Given this list of marker genes PBX1, FCRL4, ARNT, HSP90AA1, PRRX1, NTRK1 (neurotrophic receptor tyrosine kinase 1), MLLT11, SDHC, PRCC, FCGR2B (NCBI Gene Id 2213), CDC73, MUC1, BCL9, TPM3, here is a description of the gene set: from publication Myllykangas S, Himberg J, Böhling T, Nagy B, Hollmén J, Knuutila S (PMID 16751803) Human Gene Set: MYLLYKANGAS_AMPLIFICATION_HOT_SPOT_24 DNA copy number amplifications activate oncogenes and are hallmarks of nearly all advanced tumors. Amplified genes represent attractive targets for therapy, diagnostics and prognostics. To investigate DNA amplifications in different neoplasms, we performed a bibliomics survey using 838 published chromosomal comparative genomic hybridization studies and collected amplification data at chromosome band resolution from more than 4500 cases. Amplification profiles were determined for 73 distinct neoplasms. Neoplasms were clustered according to the amplification profiles, and frequently amplified chromosomal loci (amplification hot spots) were identified using computational modeling. To investigate the site specificity and mechanisms of gene amplifications, colocalization of amplification hot spots, cancer genes, fragile sites, virus integration sites and gene size cohorts were tested in a statistical framework. Amplification-based clustering demonstrated that cancers with similar etiology, cell-of-origin or topographical location have a tendency to obtain convergent amplification profiles. The identified amplification hot spots were colocalized with the known fragile sites, cancer genes and virus integration sites, but global statistical significance could not be ascertained. Large genes were significantly overrepresented on the fragile sites and the reported amplification hot spots. These findings indicate that amplifications are selected in the cancer tissue environment according to the qualitative traits and localization of cancer genes. studied in species Homo sapiens Amplification hot spot 24: colocalized fragile sites and cancer genes in the 1q21-q24 region.